The following is a description of a gene set: Genes down-regulated in comparison of TconvLN versus TregLN (see Fig. 1 in the paper for details). Human Gene Set: GSE7460_TCONV_VS_TREG_LN_DN from publication Hill JA, Feuerer M, Tash K, Haxhinasto S, Perez J, Melamed R, Mathis D, Benoist C (PMID 18024188) The transcription factor Foxp3 is usually considered the master regulator for the CD4+CD25+ species: Homo sapiens, and this is the list of marker genes: CCRL2, H2AZ1, KLRG1, SNX13, WDR82, CYP4V2, SEPTIN8, MAPKAPK3, SNX18, ST6GALNAC4, SOCS5, SESN1, NFIL3, PHTF2, ELK3, LPXN, ERGIC1, CASP7, FNTA, DPP4, GPR15, GBP2, PPM1L, CISH, NCF4, CD38, ZDHHC23, C3orf70, STON1, ADAMTS6, RORA, CXCL3, RAB8B, SMAP1, GABARAPL1, ATP2A2, DMD, CORO2A, KIF13A, SLC35D1, PTGER4, PIAS3 (NCBI Gene Id 128075), ABI2, LRIG1, TNFRSF9, GBP4, ENTPD1, ITGAE, NFKBIZ, KCNK6, CNDP2, IFT80, NCMAP, ZCCHC18, SH3BGRL2, SLC9B2, DGAT1 (NCBI Gene Id 8694), NCKAP1, TSC22D2, WLS, DNAH7, F2R, GLRX, DUSP4 (NCBI Gene Id 1846), TMEM158, TK1, CD83, OSBPL3, TWSG1, ZBED5, SLC2A3, SLC12A2, VPS54, DENND4A, AHNAK, PRICKLE1, POGLUT2, TM7SF3, RRAGD, ACADSB, CXCL1, MTMR7, AGR3, DENND5A, CCNE2, AHCYL2, TANC2, TRIM14, UBE2B, TBC1D4, CD274, FGL2, TRIM67, TDRD7, NDRG1, SOAT1, PLXNC1, MTMR3, RGS1, SH3BGRL, SNORD89, IGF1R, E2F3, ARHGAP21, UBASH3B, MATN2, BCL2L1, CCR6, ZC3H12C, ABCB1, SHE, ASNS, ITM2C, GEM, HOPX, NFKBIE, CNRIP1, LMAN1, HDAC6, SOCS2, DGAT2, PEAK1, HNRNPLL, AHR, TNFRSF1B, AXL, TMEM64, INPP5F, SLC4A7, PLCB4, RXRA, PSEN2, FBXO32 (F-box protein 32), CEP290, TRIM59, CD86, KIFAP3, ST3GAL2, CD81, TMEM65, WIPI2, PROS1, USP27X, VAV2, NIBAN3, BMP2K, GATA1 (NCBI Gene Id 2623), C9orf152, NIBAN1, CDCP1, SH3BP2, MDFIC, MGAT5, CCR8, CDK6, IL2RA, JCAD, ZC3H12D, DPY19L3, PHLPP1, ANXA4, IRF8, BLCAP, SDCBP2, MAP3K8, SERINC3, CNKSR3, ABCA5, GPR68, KLF6, HK2, LMLN, NRP1, ZNF467, PLPP1, ATP9A, LCLAT1, TTC8, RNF135, CASP4, FOXP3, TNFSF11, IRF4 (interferon regulatory factor 4), HDAC9, TNFRSF18 (NCBI Gene Id 8784), ADAP1, NT5E, PHETA2, CTLA4, IL2RB (NCBI Gene Id 3602), SAMSN1, BANK1, IL10RA, SLC22A5, FRMD6, PIK3R3, STARD5, SHKBP1, PRKRA, TGFBR1